Given this list of marker genes SLFN14, MDM2, THBS1, ABCC6, SLC34A1, D2HGDH, KCNA1, BMP6, FBP1, CCND1, CNGA3, SNCA, FGF23, ENTPD6, SMPD3, ANK3, KCNC2, RYR3, SLC41A1, here is a description of the gene set: studied in species Homo sapiens Any process that results in a change in state or activity of a cell or an organism (in terms of movement, secretion, enzyme production, gene expression, etc.) as a result of a magnesium ion stimulus. Human Gene Set: GOBP_RESPONSE_TO_MAGNESIUM_ION